The following is a description of a gene set: part of: Epigenetic regulation of gene expression Transcription of rRNA genes is controlled by epigenetic activation and repression according to the metabolic requirements of the cell. Depending on the growth state of the cell, about half of the approximately 400 rRNA genes are expressed and these have the modifications characteristic of active chromatin: unmethylated DNA and acetylated histones. Repressed genes generally have methylated DNA and histone H3 methylated at lysine-9. Regulators of activation include ERCC6 (CSB), histone acetylases such as KAT2B (PCAF), and the B-WICH complex. Dysregulation of RNA polymerase I transcription plays a role in disease.<br>The B-WICH complex positively regulates rRNA expression by remodeling chromatin and recruiting histone acetyltransferases that modify histones to transcriptionally active states<br>ERCC6 (CSB) and EHMT2(G9a) positively regulate rRNA expression by ERCC6 recruiting the histone methyltransferase EHMT2 (also known as G9a) which dimethylates histone H3 at lysine-9 within the transcribed regions of rRNA genes.<br>ERCC6 (CSB) and KAT2B (PCAF) positively regulate rRNA expression by ERCC6 recruiting the histone acetyltransferase KAT2B to the promoter where KAT2B acetylates histone H4 at several lysine residues and histone H3 at lysine-9. The acetylated chromatin facilitates the assembly of RNA polymerase I initiation complex. studied in species Homo sapiens Reactome Pathway: Positive epigenetic regulation of rRNA expression, and this is the list of marker genes: POLR1G, H2AC6, H2BC4, H2BC3, H2BC21, H3C1, CHD4, POLR2F, H2AC7, H2BC5, H2AC4, TAF1C, TBP, H2BC11, SF3B1, MTA2, POLR1H, TTF1, MYBBP1A, SMARCA5, CHD3, H2AX, POLR1C, 45S pre-rRNA gene, ACTB, H2BC15 (NCBI Gene Id 8341), H3-3A, POLR1A, H2BC12, DDX21, H2BC12L, POLR2K, H2AJ, MYO1C, H3C15, KAT2A, KAT2B, TAF1B, H2BC26, H2BC9, POLR1B, H2BC1, TAF1A, RBBP4, ERCC6, POLR2H, DEK, RBBP7, GSK3B, GATAD2A, BAZ1B, POLR2L, EP300, H2BC17, MTA1, H2AB1, POLR1D, H2AC20, HDAC2, POLR1E, H2AC18, MBD3, H2AZ2, MTA3, TAF1D, EHMT2, GATAD2B, HDAC1, H2BC14, H4C1, POLR2E, H2AC14, CBX3, H2BC13, POLR1F